Given this list of marker genes Robo2, Bmp4, Tgfbr2, Bmpr1a, Tgfb2 (NCBI Gene Id 98738), Acvrl1, Adamts5, Acvr1, Tbx2, Tgfb1, Dchs1, Twist1, Fgf8, Nos3, Tbx20, Msx2, Eng, Heyl, Smad2, Smad4, Cplane2, Bmp2, Tmem100 (NCBI Gene Id 67888), Tgfb3, Msx1, Tgfbr1, Gata5 (NCBI Gene Id 228988), Aplnr, Mdm2, Robo1, Rbpj, Bmp7, Tbx3, Bmp5, Notch1, Snai2, Isl1, Snai1, Nog, Mdm4 (transformed mouse 3T3 cell double minute 4), Sox9, Hey1, here is a description of the gene set: Mouse Gene Set: GOBP_ENDOCARDIAL_CUSHION_MORPHOGENESIS The process in which the anatomical structure of the endocardial cushion is generated and organized. The endocardial cushion is a specialized region of mesenchymal cells that will give rise to the heart septa and valves. species: Mus musculus